The following is a description of a gene set: species: Homo sapiens Human Gene Set: USF_C Genes having at least one occurrence of the motif NCACGTGN in the regions spanning 4 kb centered on their transcription starting sites. This matches the transcription factor binding site V$USF_C (v7.4 TRANSFAC)., and this is the list of marker genes: HOXC11, SH3KBP1, SATB2, MORF4L2, CCDC6, ETV4, SPATA2L, ZNF771, HHIP, LAP3, SLC31A2, TNFRSF21, ZFP91, TEF, FBL, PFDN2, GABARAP, SCFD2, FADS3, BCKDHA, LPCAT4 (lysophosphatidylcholine acyltransferase 4), PLA2G4A, RPS19, AMPD2, STMN1, EFTUD2 (NCBI Gene Id 9343), SCRT2, CTIF, SDC1, NXPH1, NPTX1, EIF5A, PA2G4, EFNB1, TXLNG, SLC4A11, RUSC1, ARX, HOXC12, H3-3A, GIT1, HSPBAP1 (NCBI Gene Id 79663), HMOX1, RUNX2 (NCBI Gene Id 860), THAP5, PRKCE, IGSF22, TMEM108, SET, SLC25A33, WDR46, PAX6, MPP3, AVP, CDC14A, RPUSD4, GTF2A1, IPO4, ADCY3, SIGMAR1, ENPP6, IKZF3, MID1IP1, HPCA, IER5L, CGN, TMEM132E, RHEBL1, PSEN2 (presenilin 2), PFDN6, B4GALT2, HS3ST3A1, CRMP1, DNAJB9, PLBD1, RRAGB, CHRM1, FLT3, SGTB, DRD1, TDRD1, FGF14, FGF6, SLC9A5, KAT6A, YBX1, MICAL2, CYP2D6, TMEM132E-DT, SYT3, PPAT, CNNM1, CACUL1 (CDK2 associated cullin domain 1), HSPA4, EIF4B, EIF4G1, MGME1, RAPGEF6, CAMK4 (calcium/calmodulin dependent protein kinase IV), EIF3J, LTBR, CLCN2, MAT2A, RPL22, METAP1D, MAX, TFAP4, RNF43, UBXN10, RXRB, NOL4L, GTF2H1, NPM1, MNT, PPP1R9B (NCBI Gene Id 84687), RPL19, DAZL, ABCB6, SIRT1, PER1, BMP4, UTP18, MYO19, BATF3, CNOT4, UBXN1, ABHD17B, HOXA3, EXOSC2, SELENOS (NCBI Gene Id 55829), WEE1, ACAP3, MXD4, LRP8, SUCLG2, ZNRF2, BCAS3, EEF1E1, KDM3A, SLC26A2, ELK1, TIMM9, IPO13, ANXA6, SC5D, DAZAP1, SLC39A7, C21orf91, GPD1, PAICS, BATF2, VGF, DCUN1D4, AK3 (adenylate kinase 3), KLF9, UBA1, GPRC5C (NCBI Gene Id 55890), NLN, LHX9, ZMYM6, DIABLO, HYAL2, VPS50, MMP23A, COL2A1, AKAP12, GNA13, KLHL28, HSPE1, SYBU, HSPH1, RAB2A, IL1RAPL1, HPCAL4, XRN2, CTSF, FCHSD2, SEMA7A, G6PC3, POLR3E, CA14, CHST11, ATOSB, ELOVL4, FGF11, SERBP1, PBRM1, TMEM47, IGF2BP1 (NCBI Gene Id 201194), MTHFD1, RORC (NCBI Gene Id 6097), MMP23B, FKBP11, HERPUD1, EXOSC5, BEND4, ADNP, PFN1, ARF6, ASS1 (argininosuccinate synthase 1, NCBI Gene Id 445), ARHGAP20, PIGW, PRMT1, JADE1, MCM8, HOXC13, SYT6, ABCA1 (ATP binding cassette subfamily A member 1), NUDC, SEZ6L, CREBRF, AGO2, ARRDC3, BHLHE40, SLC20A1, NR1D1, IVNS1ABP, PABPC4, RPL13A, BCL6, TXNDC12, INO80, ETV1, DNMT3A, NAT10 (NCBI Gene Id 79715), ALDH3B1, GK, ATXN7L2 (NCBI Gene Id 127002), TIAL1, PPARGC1B, TRMO, SOCS5, TBX4, LYAR (NCBI Gene Id 55646), TSPAN4, ENO3, HMGN2, AEN, LIN28A, ST6GAL1, SRP72, PABPC1, FHOD1, GCSH, MYCL, USP2 (ubiquitin specific peptidase 2), PSMB3, TLL1, POLR2H, NTN3, WBP2, RUNX1T1, RSPO2, POGK, ADAMTS17 (ADAM metallopeptidase with thrombospondin type 1 motif 17), CIART, PTMA, HSP90AB1, BCL9L, HOXA4, OSR1, GRK6, SLC6A15, BMP2K, SLC12A5, SNX5, DOLK, DERL3, ZBTB49, NKX2-3, GPX1, EIF4E, MAEL, ACVR2B, GRIN2A, CEACAM5, CAMKV, FARP1, GYG1, POLR2L, PDK2, CACNA1D, TIMM10, SNCAIP